The following is a description of a gene set: studied in species Homo sapiens Genes predicted to be targets of miRBase v22 microRNA hsa-miR-520a-3p in miRDB v6.0 with MirTarget v4 prediction scores > 80 (high confidence targets). Human Gene Set: MIR520A_3P from publication Chen Y, Wang X (PMID 31504780), and this is the list of marker genes: ADAM9, KDM1B, PHF14, SPTLC2, ZKSCAN1, PAF1, SERF1A, FZD6, AGO1, RFX3, GNPDA2, EDNRB, REST, PHF12, RAB5C, RYR2, LEFTY2, HP1BP3, TGFBR2, TXNIP, RUBCN, FMR1, FAM168B, TET2, PIGM, ZNF367, LRP2 (LDL receptor related protein 2), LATS2, ASF1A, FRMD4A, EPHA5, TIAM1 (TIAM Rac1 associated GEF 1), PDIK1L, CREBRF, ITPRIPL2, C6orf15, ZFYVE26, MBNL3, DRD1, DPP8, ZNF800, SON, MARCHF5, FZD3, CCSAP, TMUB2, MFAP5 (microfibril associated protein 5), DMTF1, PTPN21, KIF3B, PAK2, TRAPPC14, KPNA2, ZNRF3, MYCN, DENND5B, ZRANB1, E2F2 (NCBI Gene Id 1870), SERF1B, FSTL5, TBC1D2 (TBC1 domain family member 2), RAB11FIP1, ST7L, TBC1D8B, GUCA1C, ZNF362, R3HDM1, ELK4, RABGAP1, DDHD1, LEFTY1, MYLK, SETBP1, ABHD3, PPP6C, TAGAP, DUSP2, CCNJ, TP53INP1, APP, ZBTB5, CFL2, ZBTB33, FYCO1, ERCC4, NR2C2, SLC16A10, ATAD2, IRF2BP2, EZH1, TFAP4, JPT1, TNRC18, BARX2, MIGA2, ARL4C, TMEM123, NFIA, TMEM100, CLIP4, TSHZ3, SNX8, BCL6, SYNC, LAMA3, PTPRD, FNDC3A, YOD1, TNFAIP1, GLIS3, RUNX2, MAN1A1, RGMB, RTN1, CPEB1, RSBN1, DCAF6, PRDM4, C2CD2, LRP8, MAP3K2, TIPARP, RNF6, MCL1, RORA, UBE2Q2, ZBTB7A, GUCY1A1, ELAVL2, LCOR, DCUN1D4, PSD3, RGL1, RSF1, NR4A3, ATF6B (activating transcription factor 6 beta), RELL1, ARID4B, SLAIN1, TRIM36, MCC, NHSL3, PLAG1, SNRK, E2F7, LMO3, CYB5D2, TANC1, PAK5 (p21 (RAC1) activated kinase 5), GDF11, ARHGAP30, SLC33A1, CYBB, PARP8 (poly(ADP-ribose) polymerase family member 8), SS18L1, DNAJC27, PKHD1 (NCBI Gene Id 5314), KIF26B (NCBI Gene Id 55083), SLC15A2 (solute carrier family 15 member 2), FGD5, USP24, TMEM86A, UNC80, TNKS2, ITGB8, CNOT6, MAPK9, OLFM3, ANKRD17, SMNDC1, DYNC1LI2, MAP3K14, CDCA7, USP46, KMT5B, ROCK2, SLC40A1, EIF3M, POLQ, PHACTR4, HIF1AN, ALDH1L2, BLCAP, CYP26B1, MTF1, UBE2B, USP16, MIER3, LHX6, VDR, PDE4D, GPCPD1, DNAI7, DCUN1D1, CELF2, SMARCC2, NFIB, SSX2IP, CREB5, MSL1, GRM5, PRDM8, CUX1, E2F5, WDR37, NPAS3, PHKA1, LAMP5, ARID4A, BCL11A, TMTC2, IRF2, KAT2B, TWF1, SDC1, MTUS1, GPM6A, SLAIN2, RAB22A, CYP20A1, CORO2B, MKNK2, TET1, ADAT2, NFYA, PFKP, PLAGL2, CYBRD1, SLC24A2, ZFX, RB1CC1, ZBTB11, ZNF75A, ANKRD52, KREMEN1, SRCIN1, BCAP29, TRIP11, BTG1, TMEM64, RNF216, SHCBP1, MBD2, HIPK3 (homeodomain interacting protein kinase 3), SPRED1, ST3GAL1, QRSL1, RPS6KA3, SUV39H1, HOOK3, RASGEF1A, GPC6, CROT, HS2ST1, CUX2, ZNF827, MIXL1, C2orf69, ASAP1 (ArfGAP with SH3 domain, ankyrin repeat and PH domain 1), RAB11A, TSEN34, ANKRD13C, RRAGD (Ras related GTP binding D), PRRG1, TCAIM, GLCE, ZNF532, ARHGEF10, RBBP9, ZNF385A, FAT4, RASSF2, ASF1B, CDC23 (cell division cycle 23), OXR1, SPOP, ARHGEF17, TAPT1, RBL1, PDE8A (phosphodiesterase 8A), REEP3, CAPRIN2, CXCL1, MPC1, MED12L (NCBI Gene Id 57726), LYST, UBE2J1, HAUS8, H2AJ, INO80D (NCBI Gene Id 54891), SYTL4, PTGDR, ZC3H13, SUCO, LHX8, SKIDA1, GALNT3, COG5, JAZF1, ANO6, EXOC5, RAB11FIP5, PKD2, HDAC4, CMTR2, RELA, ARID5B, MYRF, RAD18, GPR6, TMEM170B, AMER2, VLDLR, MARCHF11, SUZ12, HECTD2, SYDE1, AAK1, SLC22A23, ZBTB41, PPARA, IKZF2, NUFIP2, ISM2, ARMC8, MICA, UNKL, FGD4, DPYSL5, TET3, SAMD12